The following is a description of a gene set: A developmental process, independent of morphogenetic (shape) change, that is required for bone to attain its fully functional state. Human Gene Set: GOBP_BONE_MATURATION studied in species Homo sapiens, and this is the list of marker genes: MBTPS2, ZBTB16, BMP2, PHOSPHO1, FGFR3, LEP, GREM1, LTF, SEMA4D, IGF1, ACTN3, IFT80, XYLT1, DCHS1, EXT1, CCDC154, EBP, THBS3, ADAMTS12, GH1, RFLNA, RHOA, RYR1, PLXNB1, ADAMTS7, PTH, SNX10, RFLNB